The following is a description of a gene set: from publication Thakar J, Mohanty S, West AP, Joshi SR, Ueda I, Wilson J, Meng H, Blevins TP, Tsang S, Trentalange M, Siconolfi B, Park K, Gill TM, Belshe RB, Kaech SM, Shadel GS, Kleinstein SH, Shaw AC (PMID 25596819) Human Gene Set: THAKAR_PBMC_INACTIVATED_INFLUENZA_AGE_21_30YO_RESPONDERS_7DY_DN studied in species Homo sapiens To elucidate gene expression pathways underlying age-associated impairment in influenza vaccine response, we screened young (age 21-30) and older (age >= 65) adults receiving influenza vaccine in two consecutive seasons and identified those with strong or absent response to vaccine, including a subset of older adults meeting criteria for frailty. PBMCs obtained prior to vaccination (Day 0) and at day 2 or 4, day 7 and day 28 post-vaccine were subjected to gene expression microarray analysis. We defined a response signature and also detected induction of a type I interferon response at day 2 and a plasma cell signature at day 7 post-vaccine in young responders. The response signature was dysregulated in older adults, with the plasma cell signature induced at day 2, and was never induced in frail subjects (who were all non-responders). We also identified a mitochondrial signature in young vaccine responders containing genes mediating mitochondrial biogenesis and oxidative phosphorylation that was consistent in two different vaccine seasons and verified by analyses of mitochondrial content and protein expression. These results represent the first genome-wide transcriptional profiling analysis of age-associated dynamics following influenza vaccination, and implicate changes in mitochondrial biogenesis and function as a critical factor in human vaccine responsiveness. Genes down-regulated in peripheral blood mononuclear cell 7d vs 0d in young adults (21-30) (responders) after exposure to Inactivated influenza vaccine, time point 7D. Comment: most (70-80%) of cohort were white, and this is the list of marker genes: NBPF11, AP1G2 (NCBI Gene Id 8906), DVL3, CLCN6, DDX56, SRRT, TNNI2, HPS4, CXorf65, SMARCD1, SCNM1, EML3, EFHD2, SLFN13, SCAP, NUCB1, MAP7D1, SPHK2, ARID3B, DAPP1, PTPRE, NOL6, N4BP1, MYADM, MAEA, WASHC1, UNK, CCL3, ACAD11, CUX1, MKNK2, GPS2, NOTCH1, LMTK3, NUP62, NCOR1P1, GIT2, SF1, AP4B1, SUGP2, PITPNM1, ZBTB40, KATNIP, NRBP2, GRB2, MAU2, RBCK1, ARRDC3, HECTD4, NAA16, MNDA, NRROS, ITGB2, WDR73, GPR137, UBA7, TMEM138, CERK, SETD1B, ATP6V0A1 (ATPase H+ transporting V0 subunit a1), ATG2A (autophagy related 2A), IL18, SNORD21, ZFP36, MZF1, ARRB2, LINC01205, IFFO1, NOP2, SPSB3, ANKMY1, MEF2D, B4GALT5, TRIM22, CRTAP, TPM2, ALOX5, ZNF486, PLXNB2, ITFG2, CDK5RAP3, LPCAT3, INTS1, LINC00294, JUND, SLC11A1 (solute carrier family 11 member 1), STX4, TRABD, IRF9, TMEM131L, SRSF2, GARRE1, CDK5RAP1, VIPR1, SGSM2, ZC3H12A, DMXL2, ACVR1B, MAP3K8, SPG7, SREBF1, TRPC4AP, AKAP17A, LYPLA1, LTBP4, SNORD68, SERPINA1, POLR1C, INAFM1, CARNS1, RIPOR2 (RHO family interacting cell polarization regulator 2), SLC25A28, SLC2A9, ANKRD11, RABL2B, ABHD3 (abhydrolase domain containing 3, phospholipase, NCBI Gene Id 90492), TNFRSF25, UBXN11, S100A4, NPRL3, MARCHF1, ZMIZ2, AMY2A, POLR2J2, P4HTM, SRSF4, GRN, FN3KRP, STX16, MED25, TUBGCP6, LZTR1, SF3B4, PDCD4-AS1, AMT, PNISR, GTPBP3, BICRA, SHCBP1, EMD, CAMK2G, CHKB, SEC22C, PLSCR3, MFSD14A, TJAP1, SLC3A2, SNORA6, ACSS2, WAS, HPS1, DNMT1, RARA, TMEM131, FRS3, NECAP1, CBLB, SF3B1, ZNF839, SMAP2, ECHDC2, MDC1, CBX4, SNORD35B (small nucleolar RNA, C/D box 35B), CDC42EP3, CDH23, PLD3, ZNF526, CDAN1, DPEP2, RNASET2, ETV3, STAT6, LILRA3, TAF6L, IKBKB, ATXN1L, TAGLN, RELCH, VAMP1, RNF126, CYTH4, ASPSCR1, RBM33, BRD9, CMTM4, BTN2A1, HLA-C, PIK3R2, SNORD10, AHR, SLC25A42, ZNF493, NR2C1, STRADA, EP300, RAF1, NBPF3, MCOLN2, SRRM2, DEF8, PIEZO1, ADHFE1, SESTD1, FOXJ2, POLG, MAP4K1, RALGPS1, USP32, SPNS1, CPSF1, NCF1, DIP2A, IER5, PABPC1, RAB27A (RAB27A, member RAS oncogene family), NPIPA1, CLIP4, CDK9, SNORD38A, C6orf136, ZNF598, BMAL1, RAX2, C11orf21, RP2, ZNF674, RASGRP4, ARAF, METTL3, ZDHHC8, RHBDF2, TNFSF12, SNORA67, MCM8, LILRA6, MNT, USP3, MRI1, MAN2C1 (mannosidase alpha class 2C member 1), EIF3CL (NCBI Gene Id 728689), CSNK1D, ZNF514, SIK3, ALKBH6, ELF4, EPN1, AAK1, HLA-DMA, LILRB3, APBB3, EIF4H, SPG21, GALT, CCNL1, AKT1, SAFB2, ADA2, BTBD2, PLA2G4B, PHACTR4, BCL3 (BCL3 transcription coactivator), NOL12, MOGS (NCBI Gene Id 7841), HCFC1, ANKRD36B, TM9SF4, CMTM7, AKAP13, ADAM19, EVL, NPIPB15, KLF2, ABR, CCL28, PHF19, MMS19, CSNK1G2, NDE1, SLC2A3, CES2, KRBA1, BHLHE40, UPK3BL1 (uroplakin 3B like 1), NDUFB4, ADCY7, IMPDH1, AGAP6, PNMA3, UFM1, CASP8, NPEPL1, RASAL3, DUS1L, TTLL3, RAB12, TMEM150A, PNPLA6, UNC119, LYN, TP53I13, CWC25, CSF3R, SLC27A3, ZDHHC1, GGA3, QSOX2, QRICH1, U2AF1L4, TTC31, GPSM3 (G protein signaling modulator 3), SNORA3B, SUN1, XPO6, LRRC14, RNASEH1, NLRP1, RHOT2, CNPY3, CDC37, MXD1, TNFRSF10B, SMARCC2, CLDN15, FUBP3, TCIRG1, DAGLB, NDUFV1, CEBPB, KRT73, WDR59, CSNK1A1P1, GUSB, PNN, SLC16A12, CIDEB, SNORD89, LINC01089, RFX1, GRK2, MCM7, LTO1, KDM2A, VPS52, PUM1, WDR37, PABPC1L, PFKL, ATG4B, TAF15, ARHGAP9, CEBPD, REPIN1, PPTC7, PPP1R3E, STING1, TMEM175, NXF1, DHRS1, GABPB2, RAP1GAP2, ARHGAP27, RAI1, PLCB2, S100Z, SPEN, MFSD10, ZC3H3, SORBS3, GSDMB, TRMT1, CUEDC1, SLC26A11, TTF2, DIDO1, ATP2A2, CTRL, COG1, JARID2, PIAS4, DICER1, RHOG, SNRNP70, GK5, METTL17, ENGASE, FUT4, GRAMD4, ITGAL, PCED1A, RUSF1, TGOLN2, CLCN7, PGS1, C1orf162, AIRE, SLC26A6, DNASE1L1, NBPF10, CBX6, OSER1, SLC8B1, SGK1, ZNF274, RAB40C, TUBGCP5, CYB561, PRKAG2, RNF216, SPOCK2, IL11RA, BTG2, ADAM8, SH3GLB2, ACADVL, C1QTNF6, TCEA2, CXCR4, PILRA, DMAP1, MKNK1, QPCT, FARSB, IP6K1, SMCR5, GSTM1, SULT1A2, TEPSIN, TRA2A, S100A10, EIF1, SLC16A5, RNFT1, CSGALNACT2, IKZF5 (IKAROS family zinc finger 5), CMIP, KHNYN, ADGRE5, STMN3, ALDOA, DNAJC28, CYTH2, IQSEC1, ZNF548, ALAD, TUBG2, CD302, ELMO2, GNAQ, HIC2, AGAP4, CHMP1B, ZMYND15, COPS7B, NFKBIA, NINJ1, TYK2, RALGDS, CREBBP, SNORD4A, PFKFB3, NSMF, ZFHX3 (zinc finger homeobox 3), FNIP1, PLCH2, D2HGDH, DUSP1, LRCH4 (leucine rich repeats and calponin homology domain containing 4), CACNA2D4, LPIN1, USP36, ARHGAP1, HGS, TRAPPC14, ANKRD36, TAF1C, SMARCA4, PBX4, CARM1, MBD6, PCSK7, HERPUD1, NLRC5, KLF10, MPEG1, LRCH3, POFUT2, MEF2A, MBD2, ASCC2, ZXDC (NCBI Gene Id 80182), PLAUR, NSUN5, ARHGAP33, RIOK3, NCSTN, REC8, TSPAN32, SSH3, AK1, SNORD36C (small nucleolar RNA, C/D box 36C), CCL3L3, PAN2, CENATAC, IDUA, WDFY2, GSTM2, SPATA20, PSAP, NFKBIZ, HNRNPM, CASZ1, LRSAM1, KLF6, RPL10, ORC6, ARHGAP4, FCGR2A, SP2, ABHD18, CSAD, ZMIZ1, DUS3L, SKIC2, WHAMM, DGKA, KXD1, ULK1, WWP2, PSMC4, GAK, RSRP1, CACNA1I, PPP1R18, ZZEF1, TBC1D2 (TBC1 domain family member 2), MTX3, ANXA11, NIBAN2, MTCH1, MICAL1, NBPF14, FBXL6, E4F1, MIR22HG, NISCH, CYTH1, ENTPD4, CXCL16, JMJD8, DGKQ, TRPT1, GRAMD1A, FGD3, ZNF275, CAPS (calcyphosine), PDE4C, LAG3, PLSCR1, SLC25A25-AS1, STX11, SYNJ2BP (NCBI Gene Id 55333), PCBP1, SULT1A1, PNPT1, PRKCD, YPEL2, CLEC7A, SMPDL3A, PATL1, C9orf72, TBC1D9B, QTRT2, RAD54L2, CLK3 (NCBI Gene Id 1198), JAK1, NKTR, PI4KA, ZYX, DNAH1, FLII, CDK11B, YJU2B, TUT4, ZFP36L2 (ZFP36 ring finger protein like 2), SNORA61, SLC44A4, AXIN1, ENO3, OSM, SUSD6, CELF2, SDE2, ITPR3, ZNF827 (zinc finger protein 827), TOGARAM2, SLC16A6, STK25, KIF21B, ITPRIP, HEXD, MAPK8IP3, OSBPL7, UBE2D3, REXO1 (RNA exonuclease 1 homolog), TXK, E2F4, ZSCAN18, KCNMB1, CNN2, NFATC2IP, LUC7L, TNK2, PILRB (paired immunoglobin like type 2 receptor beta), KLHL3, DUSP18, SHFL, GMEB2, ARRDC5, CREBZF, FAM156A, CHN2, SNX1, SLC22A18, PGAP3, POLM, PPP1R15A, LRP5L, MILR1, TMEM86B, MIDEAS, RANBP3, RSKR, PRKCSH